Given this list of marker genes DDHD2, ZNF396, CYP2U1, IDI1, RPL22, CCDC88A (NCBI Gene Id 731560), STXBP5, SEL1L, PTCH1, TMEM33, CMTR2, CWC25 (CWC25 spliceosome associated protein homolog), ARFIP1, SMAP1, ZBTB34, CA1, FERMT2, RFX7, TMCO1, MN1, NUB1, UBLCP1, CRYBG1, BCLAF3, TMEM30A, LRRC51, REPS1, TP53BP2, VCF2, MBNL1, KCTD7, CD2, RNASE11, DDX19A, AK4, FGF13, POLE2, LYST, PLPP3, AHR, HFM1, NXPH1, PAX3, CPNE8, DOCK11, ELK3, EPB41L4B, SLC25A27, MAP4K3, LURAP1L, KLHL28, WASHC2C, DCAF12L1, USP42, YTHDF3, TJP1, CDK2AP1, TASOR, DENND1B, SETD2, EPS8, FGF7, CITED2, ARMC1, SMIM9, RANBP2, RGPD2 (NCBI Gene Id 729857), CPLX4, ADGRL4, SLF2, CALM2, SMAD2, SH3GL2, PRKCA, PAFAH1B1, EXOC3, CCNE2, DNAJC25-GNG10, SREK1, PIAS2, SLMAP, RAB3IP, SDF2, BICC1, TSHZ2, PLAGL1, FAT3, BTBD3, CTNNB1, PIGK, SERPINB11, SLC47A1, TNKS, GPR6, GREM1, MFSD4A, ARL6IP1, TIPRL, RAI14, FHIP1A, CDIPT, STAR, GNG10, SNTB2, SLC28A3, OTULINL, EEF1E1, STIM2 (NCBI Gene Id 57620), RAB18, ELOVL5, PDK3, MSX2, FYB1, FRMPD1, GRM7, HBP1, CCND2, LRRTM2, VBP1, CZIB, ZDHHC6, AMOTL1, KANSL1, LAMP2, OTX2, PIP4P2, MAP4K5, TFG, CPEB2, LRCH1, ZZZ3, SESN3, FAM47B, BCL11B, TMEM135, here is a description of the gene set: from publication Chen Y, Wang X (PMID 31504780) Human Gene Set: MIR6792_5P studied in species Homo sapiens Genes predicted to be targets of miRBase v22 microRNA hsa-miR-6792-5p in miRDB v6.0 with MirTarget v4 prediction scores > 80 (high confidence targets).